The following is a description of a gene set: Sema3A, a prototypical semaphorin, acts as a chemorepellent or a chemoattractant for axons by activating a receptor complex comprising neuropilin-1 as the ligand-binding subunit and plexin-A1 as the signal-transducing subunit. Sema3A inhibits cell migration by inhibiting integrin ligand-binding activity. Reactome Pathway: SEMA3A-Plexin repulsion signaling by inhibiting Integrin adhesion studied in species Homo sapiens part of: Semaphorin interactions, and this is the list of marker genes: FARP2, RAC1, PLXNA2, RND1, FES, PIP5K1C, RRAS, SEMA3A, PLXNA4, PLXNA3, NRP1, PLXNA1, FYN, TLN1